Given this list of marker genes Adal, Tyw5, Adk, Lcmt2, Tk1, Aprt, Pgm2, Dtymk, Tyw3, Qng1, Dctd, Ak1, Pnp, Dnph1, Trmt12, Hprt1, Tyw1, Nt5e, Mtap, Ada, here is a description of the gene set: The chemical reactions and pathways resulting in the formation of glycosyl compound. Mouse Gene Set: GOBP_GLYCOSYL_COMPOUND_BIOSYNTHETIC_PROCESS species: Mus musculus